The following is a description of a gene set: from publication Cao J, O'Day DR, Pliner HA, Kingsley PD, Deng M, Daza RM, Zager MA, Aldinger KA, Blecher-Gonen R, Zhang F, Spielmann M, Palis J, Doherty D, Steemers FJ, Glass IA, Trapnell C, Shendure J (PMID 33184181) species: Homo sapiens Marker genes curated from the annotated cluster as represented in the Descartes Human Gene Expression During Development database. Human Gene Set: DESCARTES_FETAL_CEREBRUM_MEGAKARYOCYTES The gene expression program underlying the specification of human cell types is of fundamental interest. The study authors generated human cell atlases of gene expression and chromatin accessibility in fetal tissues. For gene expression, the study authors applied three-level combinatorial indexing to >110 samples representing 15 organs, ultimately profiling ~4 million single cells. The study authors leveraged the literature and other atlases to identify and annotate hundreds of cell types and subtypes, both within and across tissues. Our analyses focused on organ-specific specializations of broadly distributed cell types (such as blood, endothelial, and epithelial), sites of fetal erythropoiesis (which notably included the adrenal gland), and integration with mouse developmental atlases (such as conserved specification of blood cells). These data represent a rich resource for the exploration of in vivo human gene expression in diverse tissues and cell types., and this is the list of marker genes: MPP7, GABRE, THOC6, MPST, SEC14L5, MAP1A (microtubule associated protein 1A), GFI1B, MYO1H, RPL17P9, PTGIS, DCAF4, H3C4, ZNG1C, LINC00887, MDM1, FAM110A, VSIG10L, NT5C3A, F11R, RORC, E2F1, CAVIN2, LINC00621, GTPBP6, FERMT3, MRPL27, SMIM5, RNF215, SERPINE3, WFDC10B, TRIM58 (tripartite motif containing 58), CEP85, CYP2T1P, NUDT16, SELP, STRADB, RHAG, C1orf226, LYL1 (NCBI Gene Id 4066), FLYWCH2, BBS12, NBEAL2, ENTPD5, GATA1, FHL2, STK11, PHF13, FUNDC1, IZUMO1, ZNF582, GTF2IP14, PDGFC, ANGPT1, EGF, SMIM15, ENSG00000266767, ITGA2B, SRF, OR2W3, TAP1, TEPSIN, TLN1, CASC8, CR1L, RTL5, SLC10A3, MYO18B, THOC2, TUBGCP4, APOA1, IL21R, ATG4D, LINC01818, AKIRIN2, EXOC3L4, DUOX1, RADIL, SFT2D3, TESPA1, MAB21L1, H2AC6, FXYD5, C11orf21, TMEM91, MFSD4B, MIR4453HG, ATP2A3, BEND2, ARL1, CENPH, MEPCE, HEXIM1, PPIF, LINC02284, CD6, RIPOR3, SASS6, GP1BA, TOMM34, CALHM6 (NCBI Gene Id 441168), CEP20, CFLAR-AS1, LINC02175, SNHG6, F2RL3, DPYD-AS1, CMAHP, GAS2L1, F13A1, MPND, LTBP1, ADCYAP1, SH3BGRL2, LCA5, NEK8 (NIMA related kinase 8), ANO6, HCP5, LINC02256, H2BC21, ZSCAN25, MREG, TSC22D4, IQGAP2, LARP6, GLYATL1, GGACT, AK9, SUPV3L1, HAUS7, PTGIR, ABCB6, CHCHD7, HEMGN, TSPOAP1-AS1, MSH2-OT1, ZNF287, SLC50A1, SNPH, ST3GAL4, DCLRE1A, LGALSL, LGALS12 (NCBI Gene Id 85329), LINC00243, TSPAN33, LAT, CAPN1-AS1, FBXW10, PF4, EFCAB13-DT, ZNF175, CDC6, DAPP1, DCAF12, RITA1, PDCD6P1, TMEM40, UBE2V1P1, RAP2B, TSPAN32, LINC02166, PHF7, CMTM6, CTR9, DOK2, SYTL4, ZFP28, PSMB8-AS1 (PSMB8 antisense RNA 1 (head to head)), MMRN1, CD96, GP9, TUBA4A, RMND1, PNMA8B, ALOX12, LRRC71, CLEC12A, GP6, PSTPIP2, LINC00299, CXCL5, CD226, TECR, ENDOV, RNF141, BMAL2-AS1, PLEK, TMEM263, PKHD1L1, CD58, H2BC20P, CDHR1, ZBTB22, GRAP2 (GRB2 related adaptor protein 2), SH3BP5-AS1, CISH, B9D2, FAM167A-AS1, CMTM5, TNNC2, BBC3, TNFSF4 (NCBI Gene Id 7292), ZNF689, RASSF7, ABCA2, PPBP, MFAP3L, PLCD4, CEP44 (NCBI Gene Id 80817), MIR548XHG, MPIG6B, POC1B-GALNT4, TAF6, TGFBRAP1, OCIAD2, P2RX1, KIAA0513, FAM217B, ASB1, IRAG1, PRDM15, RNU6-501P, DOCK5, KLRD1, GPR137, AHR, RPUSD3, ZNF770, ARPC1AP4, ELOVL7, HMGB1P41, CCND3, LINC00989, THOC5, KCNJ4, H1-2, CCNJL, PRKAR2B, WDR24, COL6A3, OPLAH, CSKMT, QKILA, TFAP2E, GRM3-AS1, ENSG00000230773, CTNNAL1, PIM1, TIMM21, CALHM5, ZNF346, STON2, ENSG00000258422, THBS1, MYO3B, XK, BAZ1A-AS1, HHLA1, LY6G6F, SDC4, WASHC2A (NCBI Gene Id 88731), PIP4P2, PPP4R1L, TALDO1, RRP1, C16orf92, NRGN, OR7E14P, ADAD2, KCNC3, MPZL3, C2orf88, FOLR1, SLC44A3-AS1, C19orf48P, MZT1, SYDE2, CTSA, NAP1L5, CD69 (CD69 molecule), TUBB1, SMIM12, ACRBP, NLRC5, KEL, LINC02325, PCYT2, H2BC15, RAP1B, H2AC11, SH3TC2, MARCHF2, RNF208, CDKN2AIP, ARHGAP6, PDGFA-DT, FFAR2, DHRS12, SCTR, SLC35G5 (NCBI Gene Id 83650, solute carrier family 35 member G5), RASL11A, MFSD2B, MTURN, RHOF, DIAPH1, SLAMF6, RAB27B, LINC00964, TCEANC, S100A4, RAD9A, OR7A5, IRF2BP1, TREML1, IL27RA, LEFTY1, ZNF468, LINC01169, CD55, NFATC2IP-AS1, DLG4, ENSG00000239482, L3MBTL2-AS1, CENPT, TNFAIP8, RHD, NENF, CNST (consortin, connexin sorting protein), PELO-AS1, PADI4, UROD, ENSG00000246792, RBM38, RPL21P44, BTN3A2, DMTN (dematin actin binding protein), DNM3OS, LIPC, RNY4P19, SLC39A4, HYAL3, RPL37A-DT, GMPR, LRP12, GTPBP2, PDCL, CCDC120, MYL4, ELMO1-AS1, MTERF4, LINC00534, CMAS, MRTO4, PKN3, ABCC3, NUP62CL, HAGHL, RN7SL749P, LIPH, LANCL3, CYP1B1-AS1, DGKD, CAVIN2-AS1 (NCBI Gene Id 105373813), ZNF792 (NCBI Gene Id 126375), CXCL3, MYOM1, RHCE, OXTR, CCER2, CCDC61, TMSB4Y, DYTN, RGS18, ESS2, CD200R1, LINC02267, SDHA, TNFRSF14-AS1, ENSG00000259723, CCRL2, STOM, WNT11, LINC02476, DUSP23, STX11, ITGB3, USF1, RUFY1, HSD17B3, SIAE, IER5L, SDE2, PPP1R35, NEXN, ZNF460-AS1, RSPH14, HACD4, ARMCX5, KLHL26, LINC00598, GPX1, SPX, BANK1, SIRT7, PIRAT1, LIG4, ABRACL, IRS2, EHD3, CLDN4, RAB37, SKAP1, NR5A1, CFAP298-TCP10L, ICAM5, PTCRA, LINC02165, MAX, PRR29, PGAM1P8, RFK, PTCD2, UNC13D, SH3BP5L, PLPP7, SLC66A1, C14orf178, DPP3-DT, KCNA3, MCTP2, TJP2, SENCR, SYS1-DBNDD2, TENT5C